Given this list of marker genes Ghrl, Wnk1, Ccnb1-ps, Irgm1, Dbf4, Nrg1, Mapk8ip2, Parp6, Igtp (interferon gamma induced GTPase), Ltk, Stradb, Angpt4, Ccnd3, Eef1a1, Rptor, Nek9, Pik3r1, Acsl1, Dazap2, Tcl1b2, Etaa1, Cab39, Rgcc, Rplp1rt, Parp8, Fgf13, Tab1, Vac14, Grem1, Tcl1b5, Pak2, Ccdc88a, Map3k13, Wnt11, Ccnd1, Abi1, Il6st, Cdk5r1, Epo, Mob3a, Samd15, Ranbp2, Cks1brt, Taok1, Cab39l, Strada, Ereg, Agap2, Tcl1b1, Bmp2, Als2, Rictor, Pik3ca, Ccnt1, Bmp7, Tgfbr2 (transforming growth factor, beta receptor II), Acvr2b, Dusp19, Dele1, Slc27a1, Igf1, Fermt2, Tcl1b3, Nbn, Cd40lg, Calm2, Gprc5d, Dab2ip, Parp16, Ccnd2, Tcl1b4, Iqgap1, Nckap1l, Grm5, Mob3c, Gprc5c, Cks2, Tgfa, Pde8a, Ins1, Egf, Igf2, Daxx, Ercc6, Alkal2, Ltf, Ccnt2, Rplp1, Mob2, Erbb3, Egfr, Gprc5a, Mstn, Fam20a (FAM20A, golgi associated secretory pathway pseudokinase), Ins2, Malt1, Ngf, Spry2, Cdkn1a, Ccl5, Lamtor3, Stap1, Rheb, Epgn, Ccnk, Gdf2, Ddx3x, Adipoq, Tex24, Topbp1, Tgfb1, Dgkq, Map2k2, Ccnq, Spdya, Areg, Prkag2, Irgm2, Cdkn1b, Map3k12, Hbegf, Hmgb1, Calm3, Cd24a, Tom1l1, Map2k1, Stk11, Mtcp1, Mlst8, Mt3, Vegfa, Mob1b, Cdk5r2, Mnat1, Ajuba, Prkra, Alk, Alkal1, Bcl10, Htr2a, Pim1, Insr, Trem2, Lgals9, Gprc5b, Afap1l2, Tcl1, Gcn1, Calm1, Map3k20, Cks1b, Mob3b, Bmp4, Sav1, Atg13, Rad50, Ccnb1, P2rx7, Itsn1, Mob1a, Btc, D1Pas1, here is a description of the gene set: Binds to and increases the activity of a kinase, an enzyme which catalyzes of the transfer of a phosphate group, usually from ATP, to a substrate molecule. studied in species Mus musculus Mouse Gene Set: GOMF_KINASE_ACTIVATOR_ACTIVITY